The following is a description of a gene set: studied in species Mus musculus A process that is carried out at the cellular level which results in the assembly, arrangement of constituent parts, or disassembly of a lytic vacuole. Mouse Gene Set: GOBP_LYTIC_VACUOLE_ORGANIZATION, and this is the list of marker genes: Gnptab (NCBI Gene Id 432486), Chmp5, Oca2, Gaa, Laptm4b, Rab7, Tmem106b, Srpx, Atp10b, Pi4kb, Becn1, Rab14, Tfe3, Cln3, Abca1, Vps33a, Lipa, Lamp2, Hps4, Arl8b, Vps18, Spg11, Tmem175, Rufy4, Cln8, Spns1, Hexa, Hsd17b1, Trex1, Lyset, Ppt1, Vps35, Rab34, Tmem165, Rab20, Acp2, Rab39, Atp6ap2, Chmp4b, Lyst (NCBI Gene Id 217998), Chmp2a, Coro1a, Tmem9, Idua, Tmem199, Hook2, Hexb, Creg1, Zfyve26 (zinc finger, FYVE domain containing 26), Cln5, Zkscan3, Chmp1b2, Hook3, P2rx7, Myo7a, Arf1, Pikfyve, Chmp1a, Aktip, Chmp3, Cln6, Tpcn2, Ap5z1, Igtp, Chmp4c, Hps1, Irgm1, Flcn, Chmp7, Pla2g5, Irgm2, Mtor, Grn, Chmp1b, Clvs2, Mfsd8, Washc5, Ccdc115, Lamtor1, Hook1, Naglu, Lamp1, Arsg, Ap3b1, Rab7b, Tfeb, Fnip1, Gba1, Chmp6, Tpp1, Lrrk2, Clvs1, Syt7, Hspa8, Fhip1b, Ppp3cb, Atp6v0c, Laptm5, Tasl, Slc45a2, Mbtps1, Chmp2b, Mcoln1, Snapin